Given this list of marker genes RHAG, SLCO1B1, SLCO1B3, SPTB, ATP8B1, SLC4A1, KCNN4, PIEZO1 (NCBI Gene Id 9780), ABCB11, here is a description of the gene set: Human Gene Set: HP_INTERMITTENT_JAUNDICE Intermittent jaundice studied in species Homo sapiens Jaundice that is sometimes present, sometimes not.